The following is a description of a gene set: species: Mus musculus Mouse Gene Set: GOBP_NEGATIVE_REGULATION_OF_TROPHOBLAST_CELL_MIGRATION Any process that stops, prevents or reduces the frequency, rate or extent of trophoblast cell migration., and this is the list of marker genes: Gja1, Timp1, Arhgdib, Acvr1c, Calr, Nodal